Given this list of marker genes Tgm6, Tgm7, F13a1, Tgm1, Tgm3, Tgm2, Tgm5, Epb42, Tgm4, here is a description of the gene set: Mouse Gene Set: GOMF_PROTEIN_GLUTAMINE_GAMMA_GLUTAMYLTRANSFERASE_ACTIVITY studied in species Mus musculus Catalysis of the reaction: L-glutaminyl- + L-lysyl- =-L-lysyl-N(6)-5-L-glutamyl- + NH4+. This reaction is the formation of the N6-(L-isoglutamyl)-L-lysine isopeptide, resulting in cross-linking polypeptide chains; the gamma-carboxamide groups of peptidyl-glutamine residues act as acyl donors, and the 6-amino-groups of peptidyl-lysine residues act as acceptors, to give intra- and intermolecular N6-(5-glutamyl)lysine cross-links.